Given this list of marker genes Kat6a, Mllt6, Baiap2, Hinfp, Unc5a, Dennd4b, Tkt, Itga5, Mydgf, Gmfb, Sdc2, Agap1, Ky, Bltp2, Myo15a, Mprip, Dmpk, 9530002B09Rik, Il10, Ppp3r1, Cklf, Smarcd1, Desi1 (desumoylating isopeptidase 1), Rdx, Otud7b, Zfp395, Atg7, Thbs1, Kit, Plag1, Klhdc7a, Serpind1, Tmem164, Psg16, Sh2d7, Mdga1 (NCBI Gene Id 74762), Anapc5, Nid1, Ccdc71, Srgap2, P4hb, Apba1, Car12, Bhlha15, Mtcl2, Wipf2, Paqr7, Mapre3, Xkr7, Zcchc14, Lgi2 (NCBI Gene Id 246316), Kdm3b, Ppip5k1, Dab2ip, Dlx3, Slc9a9, Fndc10, Itgb1, Cpne5, Klhl24, Ocel1, Prkca, Impdh1, Kctd17, Slc23a2, Grk3, Ddc, Cldn12, Plce1, Parvb, Bcan, Anks3, Syk, Efr3b, Thy1, Nipbl, Bmp2, Neurog3, Scaf11, Adcyap1, Clec4f (NCBI Gene Id 97335), Elk1 (ELK1, member of ETS oncogene family), Art1, Pip4p1, Mtr, Sp4, Tk2, Bean1, Mga, Fzd7, Ube3b, Fbxl20, Ildr2, C1d, Bicd2, Phc2, Cdc14b, Zfx, Zbtb34, Slc19a3, Lgals12, Fubp3, Pdcd4, Zfyve1, Glipr2, Spata6, Mlec, Stard5, Ttpal, Cwc25, Ptgr3, Vps25, Shank2, Rab3d, Greb1l, Enox1, Cd274, Serpinb6b, Metrnl, Paqr9, Tmc7, here is a description of the gene set: Genes predicted to be targets of miRBase v22 microRNA mmu_miR_6379 in miRDB v6.0 with MirTarget v4 prediction scores > 80 (high confidence targets). species: Mus musculus from publication Chen Y, Wang X (PMID 31504780) Mouse Gene Set: MIR_6379